The following is a description of a gene set: species: Homo sapiens Urethrovaginal fistula The presence of a fistula between the vagina and the urethra. Human Gene Set: HP_URETHROVAGINAL_FISTULA, and this is the list of marker genes: IFT80, DYNC2H1, WDR35, UBR1, DYNC2I1, DYNC2I2